The following is a description of a gene set: Human Gene Set: GOCC_POTASSIUM_CHANNEL_COMPLEX An ion channel complex through which potassium ions pass. species: Homo sapiens, and this is the list of marker genes: CTTN, KCNE3, KCND2, STX1A, GRIK1, KCNIP1, KCNAB3, KCNIP2, KCNA10, CCDC51 (NCBI Gene Id 79714), KCNE2, KCNA2, KCNA3, KCNK1 (NCBI Gene Id 3775), KCNMB3, KCNQ5, KCNC3, ABCC8, DPP10 (NCBI Gene Id 57628), KCNJ4, KCNJ2, KCNE4, HCN1, HCN3, KCNA7, KCNH1, GRIK4, KCNJ5, KCNA4, KCNN1, KCNS1, KCNK6, KCNJ9, LRRC52 (NCBI Gene Id 440699), KCNE5, KCNQ1, KCNH5, KCNQ2, LRRC38, KCNK2, DPP6, AMIGO1, KCNJ8, KCNJ14 (NCBI Gene Id 3770), KCNJ16, KCNF1, KCNA6, KCNH4, KCNQ4, KCNG1, DLG4, KCNG3, AKAP9, CALM3 (NCBI Gene Id 808), KCNC1, KCNMB2, ABCC9 (ATP binding cassette subfamily C member 9), CALM1, KCNB1, KCNMA1, ABCB8, KCNMB4, KCNMB1, KCNV1, LRRC26, KCNB2, HCN2, KCNAB2, KCNE1, HCN4, GRIK3, KCNG2, SNAP25, KCNJ3, KCNG4, VAMP2, CNTNAP2, SUMO1, KCNN4, GRIK5, KCNQ3, DLG2, KCNA5, KCND1, KCND3, CALM2, KCNV2, KCNK4, KCNH2, KCNC2 (NCBI Gene Id 3747), GRIK2, LRRC55, KCNAB1, KCNC4, KCNA1, KCNJ6, KCNS3, KCNJ11, KCNS2, KCNIP3, KCNIP4